Given this list of marker genes Map3k15, Map3k12, Ripk1, Map3k1, Map3k20, Taok2, Braf, Map3k11, Map3k19, Map3k6, Map3k5, Map3k10, Map3k8, Ripk2, Map3k13, Mos, Lrrk2 (leucine-rich repeat kinase 2), Raf1, Map3k21, Map3k4, Map3k3, Map3k7, Map3k2, Araf, Map3k9, Map3k14, here is a description of the gene set: species: Mus musculus Catalysis of the phosphorylation and activation of a MAP kinase kinase; each MAP kinase kinase can be phosphorylated by any of several MAP kinase kinase kinases. Mouse Gene Set: GOMF_MAP_KINASE_KINASE_KINASE_ACTIVITY